The following is a description of a gene set: Initiation of transcription and translation elongation at the HIV-1 LTR studied in species Homo sapiens Human Gene Set: WP_INITIATION_OF_TRANSCRIPTION_AND_TRANSLATION_ELONGATION_AT_THE_HIV1_LTR, and this is the list of marker genes: HDAC8, EP300, CREBBP, SP1, SUPT5H, HDAC4, NELFE, CCNT1, PPP3CB, NFATC3, NFKBIA, HDAC3, HDAC2, NELFCD (negative elongation factor complex member C/D), NFKB1, SUPT4H1, NFATC4, HDAC7, PPP3R1, NFATC2, NELFA, NELFB, PPP3R2, HDAC9, NFATC1, PPP3CC, HDAC1, RELA, CDK9, HEXIM1, PPP3CA, HDAC5